The following is a description of a gene set: species: Mus musculus Mouse Gene Set: TABULA_MURIS_SENIS_MARROW_PROERYTHROBLAST_AGEING from publication Tabula Muris Consortium (PMID 32669714), and this is the list of marker genes: Rps19, B2m, Emp3, Jchain, Cybb, Cpne3, Rps5, Rpl10, Ndufb10, Hmgb1, Hmgb2, Rgs2, Fpr2, Top1, Cebpe, S100a6, Kif5b, Rps14, Stfa2l1, Camp, Rpl32, Rbm3, Rps17, Rpl22l1, Rps8, Anxa1, Rpl36al, Atp5pf, Son, Ltf, Rps7, Cox5b, Cyba, Rpl10a, Calm1, Rpl35, Tagln2 (transgelin 2), Fcnb, Atp5if1, Ngp, Ndufa4, Rpl8, Chchd2, Lcn2, AA467197, Cenpa, Rps2, Hmgn2, Rpl13, Il1b, Serpinb1a, Cstdc4, H2az1, Ifitm2, Orm1, Malat1, Mrgpra2b, Cd63, Rps9, Ppia, Atp5pd, Tuba4a, Chil3, Lta4h, H3f3b, Cks2, Ptma, Lamtor4, Rps18, Ndufb7, Rpl3 (ribosomal protein L3), Rpl6